The following is a description of a gene set: MicroRNAs in cardiomyocyte hypertrophy Human Gene Set: WP_MICRORNAS_IN_CARDIOMYOCYTE_HYPERTROPHY studied in species Homo sapiens, and this is the list of marker genes: MIR133B, MIR199A1, MIR185, MAP2K5, MTOR, PLA2G2A, HDAC4, CDK9, FGF2, PRKCB, PIK3R2, MIR130B, PIK3CG, IL6ST, PIK3CA, MAPK4, TAB1, DVL1 (NCBI Gene Id 348497), RCAN1, HDAC5, AGT, EGF, IGF1, NFKB1, RAF1, MIR140, PPP3CA, MAP2K1, MAPK8, PIK3R1, CAMK2D, MYLK, MIR30E, PLCB2, MIRLET7B (microRNA let-7b), MAP2K6 (mitogen-activated protein kinase kinase 6), MIR125B1, STAT3, MAPK7, CHUK, MIR199A2, CTNNB1, TNF, GSK3B, MYEF2, TGFB1, HDAC9, MAP3K14, MAPK3, MAP2K7, FGFR2, PIK3R3, IKBKE, PPP3CB, MIR214, NPPB, MIR27B, WNT5A, MAP2K4, MIR133A2, WNT3A, MIR103A1, IKBKG, MIR23A, EDN1 (endothelin 1), MAPK14, LRP5, IGF1R, PIK3CB, PIK3CD, MYLK3, ROCK1, NRG1, MIR125B2, NPPA, EIF2B5, CTF1, HDAC7, MIR21, RHOA, FZD1 (frizzled class receptor 1), IKBKB, AKT2 (NCBI Gene Id 208), MAP2K3, MIR15B, GATA4, PDPK1, MIR195, MAPK1, MIR103A2 (microRNA 103a-2), LIF, PRKG1, MIR208A, RAC1, FZD2, LRP6, CISH, MAP2K2, ROCK2, CDK7, NFATC4, CALM1, MIR133A1, AKT1